The following is a description of a gene set: Human Gene Set: TRAVAGLINI_LUNG_MYELOID_DENDRITIC_TYPE_1_CELL studied in species Homo sapiens from publication Travaglini KJ, Nabhan AN, Penland L, Sinha R, Gillich A, Sit RV, Chang S, Conley SD, Mori Y, Seita J, Berry GJ, Shrager JB, Metzger RJ, Kuo CS, Neff N, Weissman IL, Quake SR, Krasnow MA (PMID 33208946), and this is the list of marker genes: SNX8, SPINT2, KLF4, CLIC2, HLA-DRB5, DSE, CTSZ, RAB31, CXCL16, DPYSL2, ARHGAP31, SERPINF1, CTSH, AXL, CST3, GAS6, HLA-DQA1, FGL2, ALDH2